The following is a description of a gene set: A protein complex formed by the stable binding of a haptoglobin to hemoglobin. Mouse Gene Set: GOCC_HAPTOGLOBIN_HEMOGLOBIN_COMPLEX species: Mus musculus, and this is the list of marker genes: Hba-a1, Hbb-bh2, Hbb-bh0, Hbb-bt, Hbb-y, Hbb-bh1, Hba-x, Hp, Hbq1a, Hbq1b, Hba-a2, Hbb-bs